The following is a description of a gene set: part of: PTEN Regulation MicroRNAs miR-17, miR-19a, miR-19b, miR-20a, miR-20b, miR-21, miR-22, miR-25, miR 26A1, miR 26A2, miR-93, miR-106a, miR-106b, miR 205, and miR 214 and bind PTEN mRNA and inhibit its translation into protein. These microRNAs are altered in cancer and can account for changes in PTEN levels. There is evidence that PTEN mRNA translation is also inhibited by other microRNAs, such as miR-302 and miR-26B, and these microRNAs will be annotated when additional experimental details become available. In addition, coding and non coding RNAs can prevent microRNAs from binding to PTEN mRNA. These RNAs are termed competing endogenous RNAs or ceRNAs. Transcripts of the pseudogene PTENP1 and mRNAs transcribed from SERINC1, VAPA and CNOT6L genes exhibit this activity (Poliseno, Salmena, Zhang et al. 2010, Tay et al. 2011, Tay et al. 2014). studied in species Homo sapiens Reactome Pathway: Regulation of PTEN mRNA translation, and this is the list of marker genes: AGO1, MIR205, CNOT6L, VAPA, MIR214 (microRNA 214), TNRC6C, MIR26A2, MIR25, MIR21, MIR93, PTENP1 (phosphatase and tensin homolog pseudogene 1), MIR106A, MIR19B2, MIR17, MOV10, TNRC6B, MIR26A1, AGO3, AGO2, MIR106B, AGO4, MIR19A, TNRC6A, PTEN, MIR20B, MIR19B1, MIR20A, MIR22